The following is a description of a gene set: Mouse Gene Set: CUI_TREG_IFNB_RESPONSE_DN from publication Cui A, Huang T, Li S, Ma A, Pérez JL, Sander C, Keskin DB, Wu CJ, Fraenkel E, Hacohen N (PMID 38057668) studied in species Mus musculus Genes negatively differentially expressed in cell type: Treg upon treatment with cytokine: IFN-β in mouse lymph nodes in vivo. Cytokines mediate cell-cell communication in the immune system and represent important therapeutic targets. A myriad of studies have highlighted their central role in immune function, yet we lack a global view of the cellular responses of each immune cell type to each cytokine. To address this gap, the authors created the Immune Dictionary, a compendium of single-cell transcriptomic profiles of more than 17 immune cell types in response to each of 86 cytokines (>1,400 cytokine-cell type combinations) in mouse lymph nodes in vivo. A cytokine-centric view of the dictionary revealed that most cytokines induce highly cell-type-specific responses. For example, the inflammatory cytokine interleukin-1β induces distinct gene programmes in almost every cell type. A cell-type-centric view of the dictionary identified more than 66 cytokine-driven cellular polarization states across immune cell types, including previously uncharacterized states such as an interleukin-18-induced polyfunctional natural killer cell state., and this is the list of marker genes: Rgs3 (NCBI Gene Id 74699), Lamtor4, Ifi27, Cd3g, Dad1, Ephx1, Arhgap9, S100a11, Tecpr1, Arglu1, Crip1, Tma7 (NCBI Gene Id 66167), Myh9, Klf2, Arhgdib, Gnai2, Tesc, Surf1, Higd1a, Erp29, Jund, Septin9, Add3, S100a10, Fyb1, Cd52, Gimap3, Mxd4, Vim, Rgs2, Cd3d, Septin11, H2az2, Klf6, Gpsm3, Ubl3, Dusp1, Fxyd5, Ddx5, Eif1, Itpkb, Bnip3l, Hnrnpu, Stk17b, Arhgap31, Fkbp3, Ssbp3, Rhoh, Pfn1, Was, Vasp, Pfdn5, Ppp1r14b, Lgals1, Rac2, H3f3a, Ucp2, Cirbp, Arpc2, Thy1, Ndufs7, Btg2, Pou2f2, Ypel3, Sh3bgrl3, Pnrc1, Pold4, Fkbp1a, Ahnak, Sh3kbp1, Emp3, Rp9, Cdk2ap2, Hmgb1, Izumo1r